The following is a description of a gene set: studied in species Mus musculus Mouse Gene Set: GOCC_PTW_PP1_PHOSPHATASE_COMPLEX A protein serine/threonine phosphatase complex that contains a catalytic subunit (PPP1CA, PPP1CB or PPP1CC) and the regulatory subunits PPP1R10 (PNUTS), TOX4 and WDR82, and plays a role in the control of chromatin structure and cell cycle progression during the transition from mitosis into interphase., and this is the list of marker genes: Ppp1r12a, Ppp1cc, Ppp1cb, Ppp1r10, Ppp1ccb, Tox4, Wdr82, Ppp1ca